Given this list of marker genes COL1A1, TP63, ERRFI1, AHDC1, ITGA6, COL1A2, SRF, CDSN, ITGA2, ABCA12, PSEN1, VPS33B, ITGB4, here is a description of the gene set: species: Homo sapiens Human Gene Set: GOBP_SKIN_MORPHOGENESIS The process in which the anatomical structures of the skin are generated and organized. The skin is the external membranous integument of an animal. In vertebrates the skin generally consists of two layers, an outer nonsensitive and nonvascular epidermis (cuticle or skarfskin) composed of cells which are constantly growing and multiplying in the deeper, and being thrown off in the superficial layers, as well as an inner, sensitive and vascular dermis (cutis, corium or true skin) composed mostly of connective tissue.